Given this list of marker genes AGO1, SOD2, SLC6A1, AZIN1, KRTAP4-1, FAM76B, CC2D1B, MIA3, LIN28B, DDX5 (DEAD-box helicase 5), ACVR2B, ALKAL1, NTNG1, EFCAB9, FRS2, PSMD12, PBOV1, KCNK2, FAM167A, DUSP9, COL11A1, ADAMTS5, CELSR3 (NCBI Gene Id 1951), ZNG1A, ZNG1B, SCN3A, CACNB1, MIDEAS, ZHX1, LRRC58 (NCBI Gene Id 116064), INPP5K, ZYG11A (zyg-11 family member A, cell cycle regulator), CCDC28A-AS1, NVL (NCBI Gene Id 4931, nuclear VCP like), USP38 (NCBI Gene Id 84640), CALU, STX16, CCDC88A, RPL31, FAM91A1, SKAP2, SPRED1, RPP14, MED9, CSDE1, FAM227A, TJAP1 (NCBI Gene Id 93643), KDM5A, TUT4, SLC25A28, ARID1B, DYRK2, GRM3, TMEM64, AMER2, SALL1, DCC, METTL25, SALL4, GTF2H1, FBXO9, RICTOR, KLF7, SLC30A6, SOX5, KCNN3, DAAM1 (NCBI Gene Id 23002), CACNG2 (NCBI Gene Id 10369), PPM1G, SIRT1, ADCY3 (adenylate cyclase 3), LRRFIP1, NOVA1, RB1, SIPA1L2, CHD1, PGM5, CAMSAP2, TIMM9, SYN2, INAFM2, E2F5, LEMD3 (LEM domain containing 3), ZNG1C, NFE2L2, DCUN1D4, SPPL3, CCN2, VDAC2, CLMN, SLC1A3, NACC2, H2AZ1, BRWD1, MEX3C, SIX4, MUC13, RUFY3, ZNF521, CNR1, CD300LF, DPYSL3, TMEM164, G3BP2, MELK, MIER1, SETD5, BRI3, SAP30L, BOLL, AMD1, ZBTB18, BRD10, NMNAT2, SSH2, MTF2, EP300, ARMC8, ATXN1, RTN4, CDK19, ZNF652, GPATCH2L, C8orf44-SGK3, LSM11, ZNF451, USP9X (NCBI Gene Id 8239), OSBPL8, NREP, WDR5B, DAZAP2, TRNAU1AP, TLN2, MAPK1, SERP1, ASF1A, HNRNPM (NCBI Gene Id 4670), TRDN, ARID2, SS18, MEF2A, FOXO3, PAM, TSPAN6, ETNK1, NFATC2, STAG1, RAD54L2, DIPK2A, CCDC34, GPD2, MIS12, NLK, PTBP2, SPATA13, ENPP4, FEM1C (NCBI Gene Id 84463), RASA1, L3MBTL3, FBXL20, PYURF, MYCBP2 (MYC binding protein 2), ZBTB20, SLC26A7, SOX11, KCNA6, ZFP3, HNRNPH1, ATP10D, PHF12, SEPTIN8, SEMA6A, SRGAP1, TLCD5, HHIP, HBEGF, PCDH10, RGS7BP, ZNF516, KCMF1, SEC16A, MTMR10, GMFB, SGK3, CCDC71L, EPB41L5, CBLL1, here is a description of the gene set: Human Gene Set: MIR212_3P studied in species Homo sapiens from publication Chen Y, Wang X (PMID 31504780) Genes predicted to be targets of miRBase v22 microRNA hsa-miR-212-3p in miRDB v6.0 with MirTarget v4 prediction scores > 80 (high confidence targets).